Given this list of marker genes MVD (mevalonate diphosphate decarboxylase), SCARB1, LDLR, REN, DHCR24, PRPS2, PTCH2, S100A13, BTNL9, S100A16, ALAS1, LSP1, IDI1, CYP17A1, COL1A1, HSD3B2, BGN, COL3A1, INSL3, CREB3L1, THY1, ENC1, MT2A, SPARC, COL15A1, ADAMTS12, CYP11A1, IGF2, GRAMD1B, LAMB1, APOE (apolipoprotein E), CHST2, UCHL1, CALB2, MGST1, MSMO1, CILP, ANPEP, DLK1, APOC1, S100A6, HMGCS1 (3-hydroxy-3-methylglutaryl-CoA synthase 1), PAPSS2, FDX1, COL1A2, LAMA4 (NCBI Gene Id 3910), here is a description of the gene set: The reproductive and endocrine functions of the ovary involve spatially defined interactions among specialized cell populations. Despite the ovary's importance in fertility and endocrine health, functional attributes of ovarian cells are largely uncharacterized. Here, we profiled >genes in 257 regions from the ovaries of two premenopausal donors to examine the functional units in the ovary. We also generated single-cell RNA sequencing data for 21,198 cells from three additional donors and identified four major cell types and four immune cell subtypes. Custom selection of sampling areas revealed distinct gene activities for oocytes, theca, and granulosa cells. These data contributed panels of oocyte-, theca-, and granulosa-specific genes, thus expanding the knowledge of molecular programs driving follicle development. Serial samples around oocytes and across the cortex and medulla uncovered previously unappreciated variation of hormone and extracellular matrix remodeling activities. This combined spatial and single-cell atlas serves as a resource for future studies of rare cells and pathological states in the ovary. species: Homo sapiens Human Gene Set: JONES_OVARY_THECA from publication Jones ASK, Hannum DF, Machlin JH, Tan A, Ma Q, Ulrich ND, Shen YC, Ciarelli M, Padmanabhan V, Marsh EE, Hammoud S, Li JZ, Shikanov A (PMID 38578993)